Given this list of marker genes Syk, Adamts18, Emilin2, Ccm2l, Cd9, Jak1, Tnfsf11, Ccl5, Lgals1, Ank3 (ankyrin 3, epithelial), Mmrn1, Tmx1, Cd24a, Prkcq, Lyn, Alox12, Ceacam1, Ctsg, Vps33b, Prkcd, F11r, Plaur, Pdpn (NCBI Gene Id 14726), Map2k1, Prkca, Jak2, Ubash3b, Sh2b3, Emilin1, Il6, Zfp703, Htr2a, Serpine2, Rdx, Prkg1, C1qtnf1, Mfsd2b, Il6ra, Cela2a (NCBI Gene Id 13706), here is a description of the gene set: species: Mus musculus Mouse Gene Set: GOBP_REGULATION_OF_HOMOTYPIC_CELL_CELL_ADHESION Any process that modulates the frequency, rate, or extent of homotypic cell-cell adhesion.